Given this list of marker genes Crmp1, Fyn, Fes, Cdk5, Plxna1, Dpysl5 (NCBI Gene Id 65254), Plxna3, Dpysl2, Cdk5r1, Dpysl4, Plxna4, Nrp1, Plxna2, Gsk3b (glycogen synthase kinase 3 beta), Dpysl3, here is a description of the gene set: Mouse Gene Set: REACTOME_CRMPS_IN_SEMA3A_SIGNALING studied in species Mus musculus CRMPs in Sema3A signaling